The following is a description of a gene set: Any process that modulates the frequency, rate or extent of removal of phosphate groups from a molecule. Human Gene Set: GOBP_REGULATION_OF_DEPHOSPHORYLATION species: Homo sapiens, and this is the list of marker genes: ADORA1, SMG7, SMG6, MTMR9, DRD2, SRC, PPP1R17, BMP2, URI1, IGBP1, CDK5RAP3, MTMR2, EPM2A, CHRM5, MTMR3, PPP2R3C, CHP2, IGBP1C, IQGAP1, INPP5K, GPLD1, SMG5, MTMR1, CHP1